Given this list of marker genes CD81, HFE, DNAJC3, FGB (NCBI Gene Id 2244), IL2RG, ZFP36L2, GRN, PSPHP1, RNASE6, NAMPT, IGF2, CCN1, HLA-DRB5, HLA-DMB, CCL14, CXCL1, P4HA2, HLA-DOA, TSPAN3, LILRB4, HLA-C, HLA-F, IL18, GCG, IL15, KLF6, PPBP, ENPEP (glutamyl aminopeptidase), KCNN4, VIPR1, SERPINF1, ADRA1D, HLA-A, S100B, BCAT1 (branched chain amino acid transaminase 1), TIMP1, RPS27, CSF3, UBE2C, BCAR1, IL1B, SLAMF1 (NCBI Gene Id 6504), LILRB5, TPSAB1, ZEB1, TFF3, DEFA5, AREG, ERBB2, TACSTD2, CD2, SELL, CSF1, SHC1, FGF4, LY6E, EMP3, CD48, IL15RA, HLA-DRA, PDGFA, BST2, IRAK1, NAB2, IL6 (NCBI Gene Id 3569), CD69, FGA, AKR1C3, HP, EMP2, LAMP3, TGFBI, CD79A, MXD1, HLA-G, LILRA2, INSIG1, TLR1, PRDX1, PDGFB, B2M, MST1R, MYC, LILRB3, CXCL10, PDGFRA, RPS4X, CD5, LY86, CXCL5, MDK, EPS8, GAS6, OSMR, IL1A, EREG (epiregulin), CD83, FTH1, CD4, HLA-B, EDNRA, CSF3R, SELP (NCBI Gene Id 6403), HBEGF, SPOCK1, CREG1, RUNX3, CRIP1, NCF4, OSM, MTHFR, REG1B, TGFA, LILRA1, CAPN1, DAB2, NRP1, CD86, TNFSF9, IL6R, LIF, FGG, FOSL1, CDK5R1, CHRM3, BCL6, CSRP2, LRP1, ISG20, CD8A, EGF, IL3, GRPR, LRPAP1, EDN1, IGF1, EVI2A, SFN, BTG1, EMP1, PTN (pleiotrophin), CD8B, here is a description of the gene set: Human Gene Set: MODULE_223 Immune (defense) response. species: Homo sapiens